The following is a description of a gene set: species: Homo sapiens Genes up-regulated in comparison of untreated CD4 T cells at 0 h versus the cells treated with IL4 and anti-IL12 at 48 h. from publication Elo LL, Järvenpää H, Tuomela S, Raghav S, Ahlfors H, Laurila K, Gupta B, Lund RJ, Tahvanainen J, Hawkins RD, Oresic M, Lähdesmäki H, Rasool O, Rao KV, Aittokallio T, Lahesmaa R (PMID 20620947) Human Gene Set: GSE17974_CTRL_VS_ACT_IL4_AND_ANTI_IL12_48H_CD4_TCELL_UP The aim of this dataset was to study in detail the transcription kinetics initiated by cytokine IL-4 in early differentiation of Th2 cells., and this is the list of marker genes: NFKBIZ, ZXDB, TNFSF8, GSAP, LMTK2, LINC02223, WDR19, TXK, SNHG20, ARHGAP21, BRD7P3, ZNF34, KRT73, ITGA4, ITGA6, MYLIP, MARCHF2, TRIB2, ZRANB1, ADAMTS5, KLRB1, PLCXD2, WHAMM, HLA-DRA, FBXL20 (NCBI Gene Id 90110), KIFC2, TSC22D1, ATG14 (autophagy related 14), OVGP1, SIK1, IL11RA, ISCA1, ATXN1L, SECISBP2L, SGK1, BAG3, LILRB1, NR4A2, LYZ (lysozyme), SYNM, PTP4A1, GPRASP1, NSMCE3, PAIP1 (poly(A) binding protein interacting protein 1), PGAP3, IRS2 (NCBI Gene Id 90066), ZBTB20, JUN, DNAJB9, GADD45A, ITFG2, KLF11, ZNF502, TSPYL4, KLF2, MDS2, S100G, CUX1, TIGD1, ENC1, TRAPPC13, SNN, MYH11, HABP4, C9orf78, FAM200B, FAM199X, NAAA, HLA-DRB6, MEGF6, GREM1, RAP1GAP2, DHRS9, AHDC1, KAT6A, RNF139, SAMD4B, VPS9D1, SKIL (NCBI Gene Id 6498), FAM8A1, TOB1, HEG1, TSPAN32, EVI2B, OTUD1, PCSK5, ERBB2, SLC25A25-AS1 (NCBI Gene Id 286208), SLC7A6, G0S2, VAV3, IER2, CLASRP, ERO1B, TRAPPC10, MARCHF8, SOX4, JMY, RANBP17, ITPRIP, INPP5A, FAM228B, CLEC7A, DNAJB1, UBL3, TIPARP, HCK, ZNF101, KLF4, DUSP1, MAD1L1, EPHA4, BMP1, LRPAP1, MAFF, CNST, TP53INP1, ZDHHC11, DPEP2, HKDC1, C9orf72, PLEK, TENM1, TMEM254-AS1, ENPP2, EMB, DNAJC3, SC5D, IL7R, C1orf56, ZNF711, RFX3, FAM204A, MEF2D (NCBI Gene Id 4209), PLXDC1, ZFAND2A, RBM33, VCPKMT, EPB41L4A, ARRDC3, MAP4K4, SMCR5 (NCBI Gene Id 140771), FNDC3B, PRL, CXCL1, SNX29, SCML1, DSC1, KIR2DL1, MCOLN1, PDGFRL, PELI2, ITGAM, TPRG1L, GPATCH2, ATP2B1-AS1, GPRASP2 (NCBI Gene Id 114928), TRIM73, PARP8, PDCD4-AS1, LRRC37A2, SOX6, LCOR, ARIH2 (ariadne RBR E3 ubiquitin protein ligase 2), CSGALNACT1, MIR22HG (MIR22 host gene), SOCS3, ARMC2, EFHC2, SPTY2D1, TMEM132B, RASGRF2, RIMKLB, ENSG00000280119 (TEC), TPM2, HYKK, ZNF329, PIM1, GAL3ST4, TTC28, TYROBP, KAT2B, PTPRM, ZNF805, MUL1 (NCBI Gene Id 79594), PSTK, AHNAK, CRYBG1, KCNA3